The following is a description of a gene set: electronically inferred by orthology from the curated human pathway species: Mus musculus part of: Centrosome maturation This event has been computationally inferred from an event that has been demonstrated in another species.<p>The inference is based on the homology mapping from PANTHER. Briefly, reactions for which all involved PhysicalEntities (in input, output and catalyst) have a mapped orthologue/paralogue (for complexes at least 75% of components must have a mapping) are inferred to the other species. Reactome Pathway: Loss of proteins required for interphase microtubule organization from the centrosome, and this is the list of marker genes: Cep152, Csnk1e, Nedd1, Prkaca, Cep43, Cep63, Tuba4a (tubulin, alpha 4A), Haus8, Sdccag8, Clasp1, Cdk1, Haus5, Cep290 (NCBI Gene Id 216274), Tubb4a, Dynll1, Ninl, Cep192, Cep72, Cenpj, Cep41, Ywhae, Plk1, Haus7, Actr1a, Cep57, Sfi1, Dctn1, Tuba1a, Cep131, Haus1, Nde1, Tubb4b, Cep135, Prkar2b